The following is a description of a gene set: Toenail changes apart from changes of the color of the toenail (nail dyschromia) that involve partial or complete disruption of the various keratinous layers of the nail plate. studied in species Homo sapiens Dystrophic toenail Human Gene Set: HP_DYSTROPHIC_TOENAIL, and this is the list of marker genes: KIF1A, SCN9A, RETREG1, KRT14, COL17A1, RAB7A, SMARCE1, COL7A1, ITGB4, PERP, WNK1, DST, WNT10A, NOTCH1, KLHL24, KRT5, NECTIN1, ZMPSTE24, LMNA (lamin A/C), RUNX2, KRT74, IKBKG (NCBI Gene Id 8517)